Given this list of marker genes Klk1b24, Apela, Adrb1, Atp1a1, Snta1, Pmch (NCBI Gene Id 77764), Dsp, Hrh2, Abcc1, Ager (NCBI Gene Id 11596), Casr (NCBI Gene Id 12374), Atp2a2, Nr3c1, Kat2b, Dbh, Slc22a2, Slc5a6, Tgfbr3, Abat, Fxyd1, Ccl4, Mtor, Oprl1, Grk2, Adra2a, Ptpro, Fkbp1b, Vstm4, Fgg, Nos2, Calm1, Rangrf, Slc5a1, Bmp10, Plcb3, Cacna1c, Amot, Smtnl1, Slc4a3, Drd1, Kcnd2, Tbx2, Adcy6, Smad7, Klk1b1, Slc8a1, Tbxas1, Qrfp, Gjc1, Thra, Hif1a, Klk1b8, Atg5, Vegfa, Klk1b3, Htr7, Abcg2, Abl1, Adora2b, Bves, Rgs4, Pkp2, Adra1a, Fgfbp3, Myl1, Rbfox2, Kcnd3, Htr1b, Akap6, Cbs, Hrh1, Crh, Ppp1r13l, Wnk4, Mc3r, Dmd, Hrh3, Rps6ka2, Ptprm, Trpa1, Casq2, Zmpste24, Ghrl, Tgfb1, Plec, Stc1, Tmem65, Kng2, Mmp2 (matrix metallopeptidase 2), Klk1b9, P2ry1, Ppcs (phosphopantothenoylcysteine synthetase), Cps1, Ndst2 (NCBI Gene Id 17423), Gch1, Calm3, Kcnn4, Bcr, Stub1, Scpep1, Sgcg, Fgf13, Ptpn1, Ifnb1, Camk2d, P2rx4, Tmem38a, Cpa3, Ahr, Adcyap1, Apln, Arhgap35, Zc3h12a, Dusp5, Pparg, Fabp5, Mdm4, Cav1, Ace, Pebp1, Nox1, Srsf1, Sgcd, Prkca, Drd2, App, Yap1, Ren1, Foxn4, Sod1, Smpd3, Myl2, Slc6a4, Ocln (occludin), Mcpt4, Atp6ap2 (ATPase, H+ transporting, lysosomal accessory protein 2), Rhoa, Sh3gl2, Ctnna3, Ext2, Tmem38b, Uts2, Prcp, Cxcr4, Scn4b, Nppb, Kcne3, Tjp2, G6pdx, Rnf207 (ring finger protein 207), Klk1b5, Dsg2, Cx3cl1, Rnpep, Scn10a, Adra1b, Cyp11b2, Ttr, Abcg3, Plekha7, Th, Mtnr1b, Htr2b, Oxt, Slc1a5, Npff, Chd7, E2f4, Tnni1, Nedd4l, Gpd1l, Htr2c, Kcnip2, Wnk1, Dlg1, Snx5, Adra2c, Dock5, Rac1, Ar, Trex1, Acvrl1, Zeb2, Pde3a, P2rx2, Slc27a4, Kcnmb1, Scn1a, Myl3 (myosin, light polypeptide 3), Hdac4, Adamts16, Ehd3, Tac1, Sema3a, Mas1, Hsp90aa1, Tafazzin, C3ar1, Foxc2, Ace2 (NCBI Gene Id 70008), Chrna7 (NCBI Gene Id 11441), Mybpc3, Edn2, Hcn4, Il18, Add3, Fyn, Bdkrb1, Sirt1, Cfh, Guca2b, Adra2b, Abr, Map2k6, Smad6, Scnn1a, Ifng, Agtr1a, Trpm4, Abcc8, Ank2, Src, Tgfb2, Klk1b26, Klk1b11 (NCBI Gene Id 16613), Vegfc, Abcc9, Capn1, Gper1, Kl, Cacna1b, Heg1, Map2k1, Shc1, Edn1, Ccn2, Cd38, Atp2a1, Chga, Kcna5, Agtrap, Cacna1h, Npy1r, Umod, Aoc3, Zfas1, Scn1b, 3425401B19Rik, Cnr1, Ednra, Grip2, Cftr, Adm2, Chrm2, Kcnk6, Hrc, Ier3, Gsn, Rasl10b, Emilin1, Ctnnbip1, Manf, Tpm1, Or51e2, Esr2, Kcnh6, C2cd4b, Camk2n1, Egfr (epidermal growth factor receptor), Uts2r, Kcnh2, Pla2g6, Adrb3, Pln, Ptp4a3, Kdr, Tnnc1, Gnao1, Gnas, Hmgcr, Tbx18, Flna, Abcc2, Itgb1, Kcne1, Plvap, Ucn, Mef2a, Ptger3, Scn3b, Gjd3, Ryr2, Mrgprd, Chrm3, Itga1, Edn3, Nisch (NCBI Gene Id 76966), Gata6, Irx5, Scn2b, Dnm1l, Spx, Bloc1s6, Scnn1g, Klk1b21 (kallikrein 1-related peptidase b21), Lrp5, Flvcr2, Ephx2, Zdhhc21, Wdr35, Gsk3a, Klk1, Glrx3, Actc1, Kcnn2, Itga9, Htr1d, Cxcr2, Sptbn4, F2rl1, Sod3, F2r (coagulation factor II thrombin receptor), Angpt1, Avpr1a, Gnai2 (NCBI Gene Id 97505), Rock2, Gna12, Cacnb2, Tnnt2, Ext1, Slc23a2, Agtr2, Tbx20, Kng1, Calca, Gna13, Kcnk3, Klk1b4, Cacna1g, Lnpep, Gna11, Nav2, Tjp3, Adrb2, Mir208a, Hbegf, Tmem161b, Anpep, Slc2a1, Ptafr, Atp1b1, Ptger2, Myl4, Gata4, Cacna1e, Gnaq, Myh7, Abcb1b, Cyba, Kcnj2, P2ry2, Avpr2, Gpr4, Pon1, Stat1, Atp5pf, Dock4, Coro2b, Ceacam1, Trpv4, Cartpt (NCBI Gene Id 27220), Ramp2, Uty, Glp1r, Atp2b1, Pde2a, Cyp2j5, Scn5a, Apoe, Trdn (NCBI Gene Id 76757), Cxadr, Ptgs1, Rnls, Ptprj, Sod2, Vegfb, Gas6, Adcy10, Slc2a5, Nkx2-1, Sucnr1, Rarres2, Adm, Ntsr1, Thrb, Calm2, Gnai3, Nts (NCBI Gene Id 67405), Smad5, Slc1a1, Klk1b27, Znhit1, Mgll, Cd36, Crhr2, Tac4, Lep, Jup, Arhgap42, Lrp1 (low density lipoprotein receptor-related protein 1), Agrn, Gpr37l1, Isl1, Bbs2, Hey2, Tacr2, Adra1d, Dsc2, Scnn1b, Nos1ap, Pgf, Faah, Ins2, Mme, Plod3, Ncald, Mecp2, Akap9, Tnni3k, Sgcz, Alox5, Myl7, Col1a2, Ddah1, Wwtr1, Nampt, Svep1, Klk1b22, S100a1, Corin, Klf2, Ttn, Comp, Mkks, Serpinf2, Adh5, Adora1, Kcnq1, Drd3, Fli1, Gaa, Dll1 (delta like canonical Notch ligand 1), Shox2, Crp (NCBI Gene Id 98289), Asic2, Rock1, Smad3, Nos3, Gclm, Ffar3, Agtr1b, Nkx2-5, Arhgef12, Gja1, Rap1gds1, Ppard, Smtn, Nr3c2, Bbs4, Sumo1, C2cd4a, Mir1954, Ptgs2, Tcap, Uts2b, Tnni3, Ptk2, Slc22a1, Comt, Emp2, Tacr1, Nppc, Slc9a1, Atp1a2, Nmu, Foxc1, Gucy1a1, Cacna1d, Slc16a2, Cysltr1, Prep, Hmox1, Kcnma1, Pde4d, Npy, Oxtr (oxytocin receptor), Npr1, Hopx, Mylk3, Tnni2, Cav3, Slc4a5, Myh7b, Epas1, Ece1, F11r, Akap12, Prkg1, Sri, Eng, Stk39, Cdc42, Irag1, Fga, Agt, Acta2, Gpx1, Cldn5, Irx3, Popdc2, Pde5a, Kcnj5, Fgb, Abcb1a, Htr1a, Ramp3, Mfsd2a, Npr3, Drd5, Htr2a, Slc22a5, Pomc, Tacr3 (NCBI Gene Id 58183), Nr2f2, Dmpk, Pik3ca, Cacna2d1, Csrp3, Itga4, Bin1, Cdh5, Myh6, Atp2b4, Trpv1, Npr2, Kcne2, Itgb1bp1, Tbxa2r, Id2, Nppa, Ins1, Ankrd11, Pdgfb, Akt1, Icam1, Strit1, Nos1, Tbx5, Ncf2, F5, Fshr, Kcne4, Tjp1, Rgs2, Bmpr2, Bdkrb2, Tnf, Avpr1b, Ace3, Adora2a, Kcnip1, Ppara, Mdm2, Slc27a1, Ada, Ednrb, Slit2, Met, Kcne5, Enpep, Gclc, Avp, Postn, Tac2, Adipoq, Nup155, P2rx1, Klk1b16 (NCBI Gene Id 16615), Bmp6, Hsd11b2, Atp1a3, Immp2l, Sp4, Nox4, Psen2, Pik3r1, Srebf1, Kcnj8, Gja5, Fermt2, Map2k3, Per2, Emilin2, here is a description of the gene set: species: Mus musculus Mouse Gene Set: GOBP_CIRCULATORY_SYSTEM_PROCESS An organ system process carried out by any of the organs or tissues of the circulatory system. The circulatory system is an organ system that moves extracellular fluids to and from tissue within a multicellular organism.